Given this list of marker genes Mcemp1, Npnt, Syt13, Il2rg, Tmem41b, Ralgapa1, App, Nudt18, Naa11, Lcor, Neurl1b, Mrps17, Erlec1, Rad21, Lrch1, Nup160, Dbr1, Dimt1, Eya1, Ptbp3, Mtf2, Gm14743, Ncf1, Snx3, Marchf1, Klhl14, Bicd1, 4933409G03Rik, St8sia6, H2bc23, Bpifb9a, Gm3411, Naaladl2, Topors, Far1, Zfp654, Unc80, Cyp2j9, Cngb1, Mfap3l, 4930426D05Rik, Cript, Dynlt1b, Rps6ka6, Kcnc2, Arhgap27, Sh3kbp1, Gm3696, Tmtc1, Clec2h, 4930555G01Rik, Nufip2, Ptprj, Anks1b, Homez, Fpgt, Olfm3, Lyset, Nox4, H2bc24, Gmfb, Ncbp2, Bbs7, Hspa1l, Spink11, Lpin3, Me1, Frat2, Bpifb9b, Man1a, Dnajb14, Ube2a, Sftpa1, Stk32b, Trhr, Coq7, here is a description of the gene set: from publication Chen Y, Wang X (PMID 31504780) Genes predicted to be targets of miRBase v22 microRNA mmu_miR_15b_3p in miRDB v6.0 with MirTarget v4 prediction scores > 80 (high confidence targets). studied in species Mus musculus Mouse Gene Set: MIR_15B_3P